Given this list of marker genes HTR1E, NBEAL2, LINC00837, XRCC2, ESR2, PRLR, COL5A3, LRRC36, TECRL, HTRA1, HFM1, NIFK-AS1, RASIP1, ATP8B1, FAM228A, CACNA1I, FAT4, OPN5, GGH, ARHGAP28, F2RL3, MAPT-AS1, ACRBP, TBC1D17, CD177, RBM11, KLB, MED15P9, ACE2, DCLRE1C, COA1 (NCBI Gene Id 55744), BHMT2, ZNF280B, ASS1, CDKN2A, PACS1, C1orf226 (NCBI Gene Id 650140), ACTN3, DSCC1, NOMO3, OCIAD2, ZNF736, EHHADH, TMCO1-AS1, ARHGAP29, SLCO4A1-AS1 (SLCO4A1 antisense RNA 1), COLQ, PTHLH, ODAD2, ARMCX4, TRPM1, COX8C, LRIT1, ENSG00000291006, OR2C3, PCYT2, ZBTB7C-AS2, AQP10, MAGEB2, ZNF705G, ZNF701, DNAJC19, SCART1, GYG2, ZNF667-AS1, MUCL3, EPHB1, GIPC3, ZNF408, CACNA2D2 (calcium voltage-gated channel auxiliary subunit alpha2delta 2), PLEKHM3, L1CAM, SIRPB2, PAIP2B, MAL, JAKMIP3, ENSG00000293232, LGI2, SPRYD3, SCN11A, FOXD4, IQCF5, AURKC, FAM230B, TRPM6, ENG, CIB4, LINC00927, HTT, VN1R3, ZNF343, TAF1C, PCCB, FGF14-IT1, TAC1, SLC26A10P, OR5L2, C12orf54, MYH7B, GFI1, C1orf35, HHIPL2, LINC00930, MMP7, TESMIN (NCBI Gene Id 9633), REX1BD, ASB11, NTSR1, DNAL4, TSC22D1-AS1, QPRT, SHKBP1, BPIFB4, TNRC6B, TUBA4B, LINC02458, ZNF16, BCAS3, VGLL4, NKX3-2, LINC00921, SLITRK3, NR1I3, NUDT16L1, IGLV1-44, RBFA, CTAGE11P, FAM47A (NCBI Gene Id 158724), CDH8, OR7E19P, GPRIN1, KCNN1, ARFGAP3, MYO1C, MOV10L1, CD247, SFRP2 (secreted frizzled related protein 2), LINC00951, TPRN, LINC01711, H1-5, SMIM24, NOSTRIN, RGP1, PATL2, SPTB, HAPSTR2, FRMPD1, NLRP8, GTSE1, CNMD, CGNL1, MAMDC2, HNRNPA1L2, SUSD2, FCGR1A (NCBI Gene Id 50698), RD3, FAM216A, MYB, ZCCHC13, ZKSCAN5, PLA2G2F, LUZP2, CLCN2, CDY1, ABI3, LINC00052, CXorf58, DBIL5P, STMN3, RGMB-AS1, PCA3, FAM222A, TMEM51 (NCBI Gene Id 55092), AXIN1, FLJ13224, USP30-AS1, FAM83D, MTX1, ID1, ZNF775, XDH, CREG2, CTLA4, here is a description of the gene set: Four independent chip hybridization with RNAs from four independent RTOC cultures. Genes up-regulated in CD8 alphabeta OT1 thymocyte RTOC culture versus CD8 alphaalpha HY thymocyte RTOC culture. species: Homo sapiens from publication Yamagata T, Mathis D, Benoist C (PMID 15133507) Human Gene Set: GSE1112_OT1_CD8AB_VS_HY_CD8AA_THYMOCYTE_RTOC_CULTURE_UP